The following is a description of a gene set: Human Gene Set: HP_THIN_VERMILION_BORDER studied in species Homo sapiens Height of the vermilion of the medial part of the lip more than 2 SD below the mean, or apparently reduced height of the vermilion of the lip in the frontal view. The vermilion is the red part of the lips (and confusingly, the vermilion itself is also often referred to as being equivalent the lips). Thin vermilion border, and this is the list of marker genes: WNT5A, TRRAP, SHMT2, ATN1, TBX1, PPM1D, PWRN1, ADSL, PACS1 (phosphofurin acidic cluster sorting protein 1), CREBBP, CLCN3, RNU4ATAC, PBX1, FMR1, SETBP1, SMARCC2, THOC6, STXBP1, FBXO11, SARS1, CDC42, KNL1, PPP1CB, CRKL, NCAPD3, CEP63, FTO, DHPS, THUMPD1, RUNX2, RECQL, INTS11, GATA4, CTNNB1, MPDU1, GLI1, TWIST2, GNE, CKAP2L, TAF6, KDM5C, MBD5, TCF20, CNOT2, MAPK1, SLC45A1, AGO2, SMARCE1, PPP1R15B, BMP2, SRRM2, DHX9, HUWE1, MAPK8IP3, CCNK, UBAP2L, UBE3B, SMOC1, GDF1, PRORP (NCBI Gene Id 9692), KCNK4, MED12L, GAD1, MED13, PWAR1, METTL5, HERC2, LMNA, PIGK, SYNGAP1, PIK3CD, ZMPSTE24, LAS1L, NKX2-6, CASP2, HNRNPC, EXOC2, BCR, AHDC1, PIGA, STIL, NONO, FIG4, ZFPM2, WAC, COG1, ARID1B, NEXMIF, RAD21, EDEM3, KCNJ5, CACNA1C, PGM2L1, ARID1A, KDM6A (lysine demethylase 6A), H4C5, USP9X (NCBI Gene Id 8239), NDP, IRF6, GRB10, CEP152, RAP1GDS1, RAI1, ERCC6, ASCC3, BRD4, UNC80, SIN3A, GATAD2B, TBL1XR1, MPC1, CHD2, MFSD2A, KATNB1, RFX7, RALA, COPB2, SRCAP, HDAC8, PPP2R5D, FLT4, KIF14, SLC6A1, POLR3A (RNA polymerase III subunit A), TRIO, WARS1, KDM5B, TASP1, METTL23, NAA80, PSMD12, TALDO1, SATB2, DVL1, GATA5, STT3A, SNORD116-1, BCKDK, DYRK1A, OCRL, SPEN, OPHN1, CAMTA1, KCNE5, EXOSC2, JAG1, ATP6V1B2, ARX, XYLT2, TMEM94, NUP37, KDM3B, TBC1D24, B3GLCT, SMARCA4, PRKACB (NCBI Gene Id 5567), BUB1, SLC9A7, ARHGEF2, CDK5RAP2, NPAP1, WARS2, GJA5, IFT43, DDB1, ATIC, SH3PXD2B, IDH1, CITED2, DPM2, KDM1A, NALCN, HNRNPU, HIVEP2 (HIVEP zinc finger 2), AMMECR1, PURA, DPF2, CUX1, FGFR2, TRMT10A, BRAT1, PDGFRB, SLC25A24, PGAP3, MCPH1, ALG9, SLC2A1, ZFX, SEC23A, NKX2-5, ATP9A (ATPase phospholipid transporting 9A (putative)), HMGA2, CCNQ (cyclin Q), ACBD6, TNRC6B, POGZ, TRPS1, LIG4, WDR62, ASPM, RAB3GAP1, SCYL2, FAR1, ADARB1, EXT1, PIEZO2, SMARCD1, TUBGCP2, KCNJ2, PHC1, MED12, CDH11, DDRGK1, OGT, WDR19, RECQL4, EVC2, ARID2, GATA6, CDK6 (cyclin dependent kinase 6), VPS35L, COG8, CLP1, IRX5, SASS6, MYL11, CPLX1, PACS2, PCGF2, GJA1, PUF60, SMARCA2, PMM2, NSD2, AFF4, RHOBTB2, CNTNAP2, SNORD115-1, ACSL4, MKRN3, DYNC2LI1, AARS1, AGL, ANKLE2, SYT1, VAC14, ABCC9, TMEM147, COL3A1, STAG2, PYCR1, KAT6A, MEF2C, ZBTB18, ASXL2, ACTB, DNMT3A, PYCR2, ADAMTSL2, ZNF292, ADGRG6, GJA8, ALG12, RNU4-2, CHAMP1, CEP295, BBS2, CDH2, MGAT2, SIM1, AP2M1, AP3B1, SMC3, TRAPPC9, CD96, PIGU, NF1, NAA10, SMARCB1, PTRH2, TAF1, PITX2 (NCBI Gene Id 5308), KAT6B, MAPRE2, EP300 (NCBI Gene Id 2033), PRKDC, B4GALT1, CEP135, VPS51, CLTC, TTI2, SCN1A, PIGN, KNSTRN, ABL1, PRMT7, MAF, AGR2, BCL11A, COG3, MAN1B1 (mannosidase alpha class 1B member 1), IFIH1, MTOR, CDK13, IGF1R, HS2ST1 (heparan sulfate 2-O-sulfotransferase 1), WASHC4, ATRX, WDR26, LMX1B, CDC42BPB, CHST14, PIGG, DCPS, ASXL3, OTUD6B, PHIP, EBF3, SMPD4, FOXG1, PRKACA, ADNP, XRCC4, SHOC2, ANKRD11, GNAI1, MKS1, BMP1, DSE, HS6ST2, KMT2D, PIGV, SMC1A, TBCE, RPS23, TXNL4A, MCM7, TRAPPC10, ZNF526, SOX11, TRAPPC14, NBAS, PLPBP, KIF11, TLK2 (tousled like kinase 2), HK1, CDK10, UBE2A, GLUL (glutamate-ammonia ligase), CLCN6, KIF7, NIPBL, ANKRD17, SMAD4, IARS2, LMBRD1, NOG, HDAC4, CAPRIN1, OCA2, SPOP, LEMD3, ALG1, QRICH1, BANF1, RAP1B, PPP2R3C, ODC1, SNRPN, PQBP1, FBN1, BPTF, ZNF407, MEIS2, GLIS3, EIF5A, NDN, SETD5, TAF13, EVC, PDE4D, GNB2, DDX59, MYO18B, MAPKAPK5, PAK3, CIT, RNF135, ACTG1, SPECC1L (NCBI Gene Id 8221), NOTCH2, PIGQ, SOX4, ARMC9, MYMX, SLC26A2, TPR, TTC5, CSNK2A1, SON, PRKAR1B, TRIP12, KMT2A (lysine methyltransferase 2A), KDR, KCNMA1, KIF15, ROR2, AFF3, CTCF, SPTBN1, AGO1, RPL10, MYMK, STEEP1, LIFR, MID1, CENPE, MCTP2, NFIA, MAGEL2, BCL11B